Given this list of marker genes ATP8B4, ATP10B, XKR8, ABCG1, SERINC5, ABCB1, CLPTM1L, ATP8B2 (ATPase phospholipid transporting 8B2), ANO4, ATG9B, ABCB4, PLSCR1 (NCBI Gene Id 5359), XKR4, ABCA7 (ATP binding cassette subfamily A member 7), SERINC2, ANO6, SERINC3, ATP9A, MFSD2A, PLSCR4, RFT1, PLSCR5, ANO9, TMEM30B, ATP11A (NCBI Gene Id 84170), ABCA4 (ATP binding cassette subfamily A member 4), ABCA2, XKR9, PLSCR2, ABCA12, ATP8A2, VDAC2, ATP10A, TMEM30A, TMEM63A, ATP9B, TMEM63B, ATP10D, VMP1, ABCA3, ATP8A1 (ATPase phospholipid transporting 8A1), TMEM63C, ATP11B (NCBI Gene Id 348830), TMEM41B, ANO3, ATG9A, ATP8B3 (NCBI Gene Id 57203), ABCA1, ATP11C, ATP8B1, PLSCR3, here is a description of the gene set: Enables the transport of a lipid from a region of a membrane to a different region on the same membrane. Human Gene Set: GOMF_INTRAMEMBRANE_LIPID_TRANSPORTER_ACTIVITY species: Homo sapiens